The following is a description of a gene set: studied in species Homo sapiens Lack of insight (Anosognosia) is a neurological condition in which an individual is unaware of his or her own neurological deficit or psychiatric condition. Anosognosia can be associated with mental illness, dementia, and structural brain lesions and can affect an individual's conscious awareness of deficits involving judgment, emotions, memory, executive function, language skills, and motor ability. Lack of insight Human Gene Set: HP_LACK_OF_INSIGHT, and this is the list of marker genes: PSEN1, CHMP2B, SQSTM1, TBP, TYROBP, MAPT, VCP, TMEM106B (transmembrane protein 106B), TREM2, GRN